Given this list of marker genes VRK3, COQ10A, CCAR1, SIN3A, BOD1L1, TEFM, TBC1D22B, USP39, CASP2, RRP9, MED17, S100PBP, CS, STAT5B, METTL17, THRAP3, BAZ2A, DENND4A, FBXL20, KMT2A, COMMD9, DHX37, SPPL2B, DDX11, MEPCE, DDX47, CRAMP1, here is a description of the gene set: Neighborhood of CASP2 studied in species Homo sapiens Neighborhood of CASP2 caspase 2, apoptosis-related cysteine peptidase (neural precursor cell expressed, developmentally down-regulated 2) in the GCM expression compendium Human Gene Set: GCM_CASP2